The following is a description of a gene set: Human Gene Set: HP_ABNORMAL_LOCATION_OF_EARS Abnormal location of the ear. Abnormal location of ears species: Homo sapiens, and this is the list of marker genes: PTH1R, EXOC7, PLAA, EXT1, BBS9, MN1, CDH11, RERE, JARID2, IFT172, MID1, CCNK, HDAC8, EFL1, AMER1, BBS12, ATP2B1, RFC2, ALDH1A2, IFT81, EBF3, C1GALT1C1, MACF1, DYRK1A, NSD1, MYSM1, HS6ST2, TBL1XR1, EXOSC2, DLX4, TBCK, WDPCP, NDE1, ACTA1, PIGS, ZSWIM6, PIGG, DDX59, TMEM138 (NCBI Gene Id 51524), GLB1, EEF1A2, FLNB, CDC45, SIM1, CPLANE1, PEX1, PEX13, CSNK2A1, IFT122, RAB3GAP1, TUBA1A, RAB5IF, RAB3GAP2, ASCC3, DOCK6, ZMPSTE24, GTPBP2, NAA10, PEX26, SRCAP, PURA, CPLX1 (NCBI Gene Id 10815), PPP1R21, BBS1, ADAT3, ZNF292, ALG9, LMBRD1, GFRA1, SATB2, GNE, BUB1 (NCBI Gene Id 699), MEF2C, RAI1, TUBB3, EFTUD2, SMC5, PEX5, DNMT3B, ARVCF, HSPG2, ASXL1, EXOSC9, TRIP12, PAM16, B4GAT1, LIG4, SON, TPM3, UBAP2L, RNASEH2A, GATA1, RIPPLY2, USP7, SLC12A2, TCTN3, ADAR, PAFAH1B1 (NCBI Gene Id 5048), CCDC22, ATP6V1A, KIF26A, WNK3, GPT2, ATP6V1E1, RPS15A, HYLS1, FKTN, SLC1A4, FANCB, RNASEH2C, TRPV6, NSUN6, FOXL2, SPRED2, USP9X, SOX11, PYCR1, PLOD3, DVL1, NAA80, IRX5, EDNRA, KIF7, OTUD6B, B4GALT7, MESP2, ATP6V0A2, SDCCAG8, PRRX1, RXYLT1, NEK9, RNU4ATAC, SPRED1, PLXND1, OTX2, MKKS, TMEM70, GABRA3, CBY1, ZNF462, KIF21A, PNPLA6, C2CD3 (NCBI Gene Id 26005), TBC1D24 (NCBI Gene Id 57465), NOTCH2, MYO9A, TAF6, TRPS1, GLIS3, NELFA, MAD1L1, NRCAM, SETD1A, CDCA7, CEP104, CCNQ, TOGARAM1, BRD4, FGF20, ALX1, RPS26, KATNIP, JMJD1C, RPL18, JAG1, SLC3A1, RPS28, WASHC5, MADD, FGF10, FRA10AC1, BBS2, HEATR3, CHRND, KCNH1, SOX5, COLEC10, UMPS, WNT3, CHAMP1, DSE, WBP4, CRLF1, SETD5, ELN, RPS7, CACNA2D1, TMEM147, ORC4, VAMP1, PSAT1, TMEM260, PRKAR1B, SLC39A8, NAA60, CEP152, PYCR2, VPS35L, MYMX, CAMK2G, GJA5, DHCR7, RARB, RYR1, TRIP13, SCO2, RPL11, UPF3B, CDC42, BUD23, KIFBP, INTS11, BBIP1 (BBSome interacting protein 1), RPL27, UBE4B, TWIST1, LARGE1, CRELD1, NEU1, ZDHHC9, DEPDC5, MITF, ORC1 (origin recognition complex subunit 1), PIK3R1, RPS27, MED12, SETBP1, KAT8, RAPSN, ATR, GNB2, SCNM1, CEP55, MAP2K2, POLE, DDX6, RPL15, BRF1, TALDO1, LETM1 (leucine zipper and EF-hand containing transmembrane protein 1), SYNGAP1, CNOT2, ESAM, RALGAPA1, SMPD4, ORC6 (origin recognition complex subunit 6), MASP1 (MBL associated serine protease 1), RUSC2, UNC80, SNAP25, MAP3K7, ITGA8, BUB1B, FANCD2, B3GLCT, OSGEP, ARX, CSGALNACT1 (chondroitin sulfate N-acetylgalactosaminyltransferase 1), HMGA2, ZIC3, SCYL2, CDKN1C, MPDZ, SPECC1L, ATP6AP2, RSPRY1, NRAS, STXBP1 (NCBI Gene Id 6812), EIF3F, RPL9, RPGRIP1L (RPGRIP1 like), FGFR1, CCN2, PIGU, ESCO2, TAPT1, DHX16, GNPTAB, RAD21, ACAN, BMPER, OCRL, CD96, CNTNAP1, MEIS2, SMAD2, DAG1, WASHC4, GTF2H5, ATP6V1B2, PIEZO2, BLTP1, IGBP1, CACNA1C, NTNG2, TOPORS, PSMD12, STAC3, POLR1B, BUB3, ERMARD, SRD5A3, PUM1, MBD5, COL13A1 (NCBI Gene Id 96775), RREB1, EP300, MAF (MAF bZIP transcription factor), ADNP, GPRASP2, ATIC, XYLT1, IREB2, DZIP1L, ADSL, WDR35, LRP2, PDPN, RPL35A, ADAMTS15, DDR2, PAICS, SMARCA2, ACOX1 (acyl-CoA oxidase 1), KMT2D, POLR1C, BMP2, ZNF148 (zinc finger protein 148), NUP188, NCF1, MYO18B, SMG9, COG8, EDEM3, MAN1B1, HRAS (HRas proto-oncogene, GTPase), PTEN, HMGB3, EIF4H, ZNF423, PPM1D, POLR1A, DHODH, VPS33B, ASXL2, LZTR1, AP3B1, SOS1, KDM6A, ACTG2, MED27, EPG5, DPYSL5, PAX1, FOXP2, GTF2IRD2, LMNA, ALG6, SCN4A, ALG2, TMEM107, ZMIZ1, COG5 (NCBI Gene Id 10466), UBE3B, DNM1, KDM5A, TBCE, TGFBR1, RAB34, SMAD4, KCNJ5, WNT7A, RPL10, PLCH1, WAC, HOXD13, CPT2, POMGNT1, ANKRD11, NPHP1, WNT9B, PDZD8, WNT7B (Wnt family member 7B), IFT56, RPS10, ERI1, PORCN, CDC42BPB (CDC42 binding protein kinase beta), B3GAT3, CCBE1, MECP2, DHX9, SIX2, ZFX, CDT1, MCTP2, PUS7, MUSK, CEP41, HES7, DONSON, TEFM, SMOC1, FIG4, RTL1, ZBTB20, FUCA1, LRRC8A, SLC37A4, NFIA, MRPS16 (NCBI Gene Id 64959), PEX14, PPP2R5D, AFF3, SLC6A9, MRPS28, KLHL40, PHACTR1, SKI, PIGN, SCARF2, DLL3, MINPP1, AKT1, ALDH18A1, FGF3, RPL26, FDFT1, NUP88, NARS1, TWIST2, SMARCD2, GLI3, DHCR24, SRRM2 (serine/arginine repetitive matrix 2), COL2A1, EZH2, WNT4, CTBP1, RTTN, PUF60, RIT1, TTC5, CASZ1, SOX4, RAB18 (NCBI Gene Id 22931), IFIH1, SOS2, NOTCH3, BRPF1 (NCBI Gene Id 7862), TBX2, RDH11, WNT5A, WDR37, GK, PRUNE1, KIAA0753, ZEB2, PRR12, METTL27, SEMA5A, NF1, BCL11B, ANTXR1, POLR1D, TBR1, SEMA3E, GLE1, TXNDC15, MBTPS1, RPS23, BBS10, CDK10, CTCF, EIF4A3, ECE1, KIF15, RNU4-2, SPINT2, PIBF1, ALX4 (NCBI Gene Id 64068), B3GALT6, POMT2, LZTFL1, CDK13, OFD1, COG1, RAB23, FRAS1, UBR7, TGDS, TCF20, BBS4, SET, KCNJ2, TCTN1, TAOK1, SPART, AGRN, STRA6, RECQL4, LFNG, HOXB1, IFT140, CAMKMT, COL4A1, VPS37D, WARS2 (tryptophanyl tRNA synthetase 2, mitochondrial), OGT, PRDM16, PEX16, TFAP2B, SCAPER, SUFU, KCTD1, RAF1, TBC1D20, POMT1, SHOC2, TLK2, GREB1L, LSM11, PEX19 (NCBI Gene Id 7835), RPS24 (NCBI Gene Id 6229), ANKH, KAT6B, CRPPA, MAPK8IP3, GNAI3, GRIP1, MTHFR, MAPK1, SOX6, H4C3, OTUD5, EBP, ADAMTS2, DYNC2LI1, SMC3, UFC1, PEX10, NR4A2, PEX6, H4C5, CC2D2A, AP1G1, CEP19, CLIP2, RNU7-1 (NCBI Gene Id 100147744), RIPK4, RRAGC, PIGT, TRIM32, CHAT, FREM2, INPP5E, GPKOW, RRAS, ACTB, XYLT2, BCL11A, FBXL4, HBA2, RBM10, FBXO11, PRPS1, MYOD1, KDM4B, IL6ST, MAP1B, DPH1, TMEM94, SIAH1, DNAJC30, ATN1, PCNT, HS2ST1 (NCBI Gene Id 9653), TAF1, HNRNPH1, PLCB4, FAM20C, RRAS2, SKIC3, BCOR, SUPT16H, TRPV4, DHPS, GPC4, GJA1, FHL1, CTNND2, STAG2, BICRA, TCOF1, CASP2, DPH2, TENM3, AIFM1, EYA1, PRKG2, DVL3, LARP7, SLC25A1, INTS1, GON7, ARL13B, LMX1B, B4GALT1, IGF2, CDH2, PIGB, GATA4, CDC6, PACS1, PTCH1, MRPS22, EXOC2, VANGL2, NSRP1, COMT, FLI1, TMEM216, TSPEAR, GALNT2, EDN1 (NCBI Gene Id 1906), CEP290, CEP120 (centrosomal protein 120), SF3B4, MED13L, ERCC1, YWHAE, UBA2, RPS20, FKRP, TMEM270, PPP1CB, GNB1, CCDC47 (coiled-coil domain containing 47), LMOD3, CHRNA1, TCTN2, PRKDC, ANO1, CLCN3, BAP1, PTF1A, GTF2I, PRIM1, SMS, NXN, FN1, FREM1, UHRF1, TFE3, UFD1, PAX7 (paired box 7), BRCC3, RBM8A, HMX1, TRIP11, GAD1, SEC24C, ADAMTS3, MGAT2, CHUK, IGF1R, PHGDH, NALCN, LIMK1, TFAP2A, TMEM165 (transmembrane protein 165), DRG1, KRAS, SPEN, ARL6, MAP2K1, TMEM231, MRPL12, SAMHD1, CHD4, MYCN, NAA20, SLC4A10, RPL8, RPS19, ALG8, SYT2, POMK, STAG1, INTU, GBA1, FZD2, POLR3A, CBL, ZNF699, GNS, RELN, ZBTB18, AFF4, LRPPRC, KIF14, CHRNG, ARMC9, GTF2IRD1, QRICH1, PEX11B, KLHL41, NFIX, EED, SH3PXD2B, RFX7, FOXF1, KCNK4, BBS7, IFT52, FLNA, DLK1, RNASEH2B (NCBI Gene Id 79621, ribonuclease H2 subunit B), TMEM237, TPM2, TREX1, DPF2, CNOT3, MED25, CTU2, CHD5, COX7B, BRAF, SUZ12, GPC3, ANTXR2, NHS, DHX30, KATNB1, ZC4H2, POR, SATB1, HSD17B4, CFAP418, TASP1, HIRA, MEG3, CNOT1, INSR, TBX15 (T-box transcription factor 15), AUTS2, STAMBP, CENPJ, TTC8, ROR2, RPL31, B3GALNT2, ACER3, CSPP1, MAB21L1, RSPO2, INPPL1, MARS1, PTPN11, ARL3, ARID2, KANSL1, CHST3, C12orf57, KMT2A, GJA8, NGLY1, METTL5, PREPL, KAT5 (lysine acetyltransferase 5), CEP57, POC1A, PKHD1, CTSD, AP3D1, SLC18A3, FAM149B1, EIF5A, RPL5, PRDX1, GLUL, MCM5, MYH3, CWC27, MESD, ERCC5, AHI1, MMACHC, ATRX, COL11A2 (collagen type XI alpha 2 chain), NECTIN1, RB1, VAC14, CENPF, TRAF7, VIPAS39, IFT27, DOK7, MRPS2, THUMPD1, CAMTA1, SEPTIN9, CHD7, HDAC6, PEX2, SMC1A (NCBI Gene Id 8243), BMP4, BAZ1B, SMG8, ZMYM2, RAP1B, COG3, PLAG1, GLI2, FBLN5, FOXE1 (forkhead box E1), DST, PBX1, OCLN, PLVAP, STX1A, PAX3, ZBTB24, CHD8, PCLO, SOD1, PEX3, ERCC4, NIPBL, COLEC11, RPS17, MAGEL2, KAT6A, LBR, TMCO1, SOX9, FKBP6, GABRD, ALX3 (ALX homeobox 3), MSL3, WBP11, CILK1, RMRP, GP1BB, RALA, CHST14, KIAA0586, HELLS, RPL35, IFT74, NSD2, MRAS, MRPS14, FGFR3, CHMP1A, PPM1B, BMPR1A, UGP2, TAF4, IPO8, MBTPS2, ACP5, CACNA1G, ASXL3, RPGRIP1, MEGF8, PPP1R12A, B9D2, FGFR2, FBN1, SPOP, TRRAP, POGZ, TMEM67, ASH1L, ALG13, COG7, FRMD4A, PITX1, CHSY1, EFEMP2, DIS3L2, SCLT1, RAP1GDS1, VARS1, H4C9, MARS2, KYNU, HERC1, LIFR, HUWE1 (HECT, UBA and WWE domain containing E3 ubiquitin protein ligase 1), MMP23B, CAV1, MAPRE2, GPC6, PDE6D, CREBBP, NSDHL, TBL2, DCPS, TTI1 (TELO2 interacting protein 1), QARS1, BBS5, CHD3, TUBB, ADGRG6, ADA2, H3-3A, LUZP1, FGD1, GPX4, RPS29, CUX1, RASA2, NEB, SLC5A7, RET, PRKCZ, PEX12, U2AF2, NSUN2, SLC25A24, ADAMTS18, TOE1, DDB1, TBX1, POMGNT2, B9D1 (NCBI Gene Id 27077), PPP2R3C, COL11A1, PCDHGC4, MKS1, TMEM218, CANT1, RAC1, GMNN, TSR2, DDX3X, KMT2B, HBA1, YY1, FANCL, PLAAT3, SLC26A2, WDR73, FAT4, MVK, ARID1B, ITCH, AHDC1, SNRPB, PHOX2B, SRY, KCNAB2, TTI2, PCGF2, PIGV, PDE4D